Given this list of marker genes Acadm, Acot11, Acot5, Hadha (hydroxyacyl-CoA dehydrogenase trifunctional multienzyme complex subunit alpha), Pccb, Mecr, Hadhb, Eci1, Dbi, Pctp, Acot9, Pcca, Acot13, Acsf2, Mcee, Acot1, Mcat, Acadl (acyl-Coenzyme A dehydrogenase, long-chain), Mmaa, Acot3, Acaa2, Hadh, Acot7 (NCBI Gene Id 70025), Ndufab1, Acads, Acadvl, Decr1, Mmut, Acot12, Acad11, Acbd7, Them4, Acad10, Acot2, Them5, Acbd6, Echs1, here is a description of the gene set: Mitochondrial Fatty Acid Beta-Oxidation species: Mus musculus Mouse Gene Set: REACTOME_MITOCHONDRIAL_FATTY_ACID_BETA_OXIDATION